Given this list of marker genes E2f5, Cacnb1, Ryr2, S100a1, Ryr1, Mrln, Gsn, Sgcd, Thbs1, Manf, Cmya5, Pygm, Mb, Slc8a3, Dhrs7c, Cthrc1, Akap6, Akap7, Nos1, Asph, Hk2, Sertad1, Atp2a2, Reep5, Strit1, Scn3a, Hax1, Calr, Syne2, Dtnbp1, Itpr1, Car4, Bag5, H6pd, Sri, Zfas1, Hsp90b1 (heat shock protein 90, beta (Grp94), member 1), Slc2a4, Ank1, Myh10, Hrc, Atp2a3, Irag1, Gstm7, Flnc, Ccdc78, Tmem38a, Klhl41, Nfatc1, Plec, Agl, Elavl1, Sar1a, Fabp3, Casq2, Camk2g, Itpr2, Mtmr12, Col6a1, Itpr3, Habp4, Ank3 (ankyrin 3, epithelial), Serpinb5 (NCBI Gene Id 98414), Cherp, Trdn, Fkbp1a, Rtn2, Slc30a7, Spock1, Mef2c (NCBI Gene Id 71350), Atp2a1, Camk2b, Nol3, Srl, Jsrp1, Art1, Oprm1, Jph2, Xdh, Camk2d, Cacna1s, Ryr3, Fkbp1b, Bcl9, Pln, Baalc, Cacna2d1, Rasd1, Cavin4, Akt2 (thymoma viral proto-oncogene 2), P3h2, Thbs4, Fsd2, Stim1 (stromal interaction molecule 1), Dmpk, Ifrd1, Pomt1, Ankrd2, Sln, Nox4, Kcnma1, Calu, Jph4, Oprk1, Nos1ap, Tnnt2, Casq1, Tmem109, Jph3, Jph1, here is a description of the gene set: species: Mus musculus Mouse Gene Set: GOCC_SARCOPLASM The cytoplasm of a muscle cell; includes the sarcoplasmic reticulum.